Given this list of marker genes PIK3CD, PRKCZ, HGS, VAV1, ITGA11, CDC42 (NCBI Gene Id 998), YES1, GNB1, CFL1, PTPN11, ITGA7, PTPN6, CD3D, STAT5B, CRK, HLA-DRA, SRC, MAPKAP1, BAD, BLK, VPS4B, PTK2, RHOA, ITGA2, RAC1, CD3G, CD4, RACK1, ITGB1, PLCB1, STAT3, FGR, CXCL12, SSH1, GNG2, ITGA8, PLCB3, GNAI1, ITGAV, ITGA1, HCK, PXN, GNAO1, FOXO1, ITGA4, ITGA10, MMP9, PTEN, PIK3CB, ARR3, PTPRC, ITGA9, STAT5A, CD3E (NCBI Gene Id 916), DNM1, GNAZ, PIK3R3, PIK3CA, RAP1B, ITGA6, VPS4A, AKT1, CXCR4, PTK2B, PIK3R2, MTOR, RGS1, ITGA5, CSK, GNA13, RHOB, RALB, ARRB2, LCK, UBQLN1, PIK3R6, CD247, BCAR1, PIK3CG, FYN (FYN proto-oncogene, Src family tyrosine kinase), MLST8, STAT1, RICTOR, PIK3R1, GRK2, PIK3R5, GNAI2, STAT2, ITCH, PAK1, ITGA3, LYN, JAK2, PDPK1, PLCB2, GRK6, LIMK1, PAG1, GNAI3, RHOC, here is a description of the gene set: CXCR4-mediated signaling events from publication Schaefer CF, Anthony K, Krupa S, Buchoff J, Day M, Hannay T, Buetow KH (PMID 18832364) Human Gene Set: PID_CXCR4_PATHWAY studied in species Homo sapiens